Given this list of marker genes JMJD1C, PTEN, MCM10, WAS, FREM2, LTBP4, KMT2D, ORAI1, UFD1, HIRA, SKIC2, G6PC3, VANGL2, AK2, RAG2, EPG5, NKX2-6, ARVCF, FOXN1, SKIC3, CDKN1A, ADA, ERCC8, POLR1C, FRAS1, IL2RG, PLXND1, CDKN2C, AKT1, SEC24C, POLR1B, CDKN1B (NCBI Gene Id 1027), TCOF1, TBX2, NUAK2, GP1BB, TTC7A, NEK9, ANTXR2, WIPF1, CDKN2B, ALG14, PEX5, RREB1, MEN1, RAG1, DCLRE1C, TFAP2A, NSMCE3, TP63, POLR1D, ATM, CHD7, RORC, POLR3A, PI4KA, COMT, TBX1, MTHFR, POLD3, here is a description of the gene set: Human Gene Set: HP_ABNORMAL_THYMUS_MORPHOLOGY Abnormality of the thymus, an organ located in the upper anterior portion of the chest cavity just behind the sternum and whose main function is to provide an environment for T lymphocyte maturation. species: Homo sapiens Abnormal thymus morphology